Given this list of marker genes ITGB1, SYDE1, RAPGEF2, VCP, ARHGAP11B, RGS8, THY1, SNX18, AGRN, NET1, TBC1D30, BMP2, RASGRP2, PSAP, RALGAPB, RPS3, RAP1A, SNX9, TBC1D2, TBC1D7, TIAM1, PIP5K1A (NCBI Gene Id 8394), RALBP1 (ralA binding protein 1), SIPA1L1, PLXNB1, SRGAP2, ODAM, APC2, SGSM2, FGFR2, CR1, ARHGEF16, DOCK10, ALS2, RGS7, RHOG, HSPA1A, CCDC125, RAB11FIP2, RACK1, SNX13, TANK, LARS1, PCNA, PRTN3, F2RL1, SGSM3, RALGAPA1, SEMG2, RALGAPA2, ZC3H15, GRN, MBP, GPLD1, ECT2, SYDE2, EPHA2, RGP1 (RGP1 homolog, RAB6A GEF complex partner 1), RHOA, RAPGEF3, ARHGAP42, EVI5, PLIN5, BCR, TBC1D20 (NCBI Gene Id 170488), USP17L2, RIC1, WRN, RSU1, S100A10, LIMS1, RTN4R, ARAP1 (NCBI Gene Id 23290), RAPGEF6, VSIR, AKT1, DVL3, RAP1GAP, RHOC, PLA2G5, SEMA4D (NCBI Gene Id 349236), RAB3GAP1, ASAP3, RAPGEF1, RGS16, TGM2, ABR, PNLIP, BCAR3, SH3BP1, SCRIB, GNB5, MMUT, PRSS22 (serine protease 22), ARHGAP11A, RGS10, EVI5L, EZH2, FGFR1, DOCK11 (NCBI Gene Id 139818), NF1, ADCYAP1, RGS6, TSC1, DOCK8, ITGA6, CHP2, RCN3 (reticulocalbin 3), GBA3, SEMG1, RANGAP1, PRELID1, FGFR3, NTRK1, SERPINB3, DOCK9, CORO1C, ARHGEF7, PSENEN, RGS1, PRKCD, MTSS2, MTMR9, USP6NL, RASGRP1, NDEL1, here is a description of the gene set: Any process that activates or increases the frequency, rate or extent of hydrolase activity, the catalysis of the hydrolysis of various bonds. studied in species Homo sapiens Human Gene Set: GOBP_POSITIVE_REGULATION_OF_HYDROLASE_ACTIVITY